Given this list of marker genes DPYS, SLC2A1 (NCBI Gene Id 6513), TSEN2 (NCBI Gene Id 80756), TSEN54, ACAT1, C9orf72, here is a description of the gene set: species: Homo sapiens Extrapyramidal dyskinesia Human Gene Set: HP_EXTRAPYRAMIDAL_DYSKINESIA